The following is a description of a gene set: studied in species Homo sapiens The directed movement of substances into, out of, or within the nucleus. Human Gene Set: GOBP_NUCLEAR_TRANSPORT, and this is the list of marker genes: XPO5 (exportin 5), TNPO2, AKAP8L, LZTS2, NUP85, UHMK1, EIF4E, PTTG1IP, HDAC3, NRDE2, ATXN1, RPL23, CTDSPL2, XPO6, NUP35, IL1B, CDAN1, HSPA9, NUP62CL, THOC7, NPM1, ANKLE1, NUP160, EIF6, LEP, HCLS1, CDKN1B, DMAP1, C12orf50, IER3, PPP1R12A, PKIA, SHH, TSC2, SIRT6, KPNA1, CDKN2A, ZIC1, THOC2, KPNA7, SETD2, HIKESHI, PHB2, PARK7, RGPD3, THOC3, RAPGEF3, NFKBIA, DDX39B, EP300, THOC5, MAPK14, SFN, ZC3H12A, FAM53C, ING1 (inhibitor of growth family member 1), NUP43, AKT1, WNK1, CWH43, UPF2, ENY2, CFL1, RANBP1, SIX3, CPSF6 (NCBI Gene Id 11052), NR4A1, CDK1, TRAF3IP2, AHCTF1, MDN1, CCHCR1, YTHDC1, BAG3, PKD1, HEATR3, NUP107, TNPO1, DDX25, XPOT, FMR1, SRSF3, STRADA, TERT, FCHSD1, RAB23, PPP3R1, FERMT1, MED1, SMG7, NPAP1, TPR, NUP133, SARNP (SAP domain containing ribonucleoprotein), BCL3, UFM1, EPM2A, YWHAE, ZC3H11C, BMP4, GLI3, POLA2, RBM8A, HNRNPA1, RBM10, XPO4, MCM3AP, RANBP2, UBE2I, NSUN2, NXT2, CRY2, GAS6, EIF4A3, STRADB, PTPN14, CITED1, FRAT2, ANKRD54, PIK3R1, RPAIN, RBM15B, NEDD4, NEMF, TRIM28, THOC6, RGPD5, NXF1, SPG11, NMD3, SQSTM1, ZC3H11B, ADAR, SEH1L, PML, STAT3, RBM22, MAGOH, CHTOP, IPO11, STK3, TARDBP, HYAL2, ANP32B, AGFG1, RBM33, APPL1, NUP155, IPO4, NOTCH1, DRD1, TNPO3, SDAD1, CABP1, NUP93, SYK, KHDRBS1, RAN, KPNA2, NUP88, KPNA4 (NCBI Gene Id 84857), FGF9, JAK2, FAM53A, SMG5, SSB, APOD, EMD, PRKCD, NXF3, MX2, NCBP1, HHEX, SMG1, NUP188, HTATIP2 (HIV-1 Tat interactive protein 2), TMCO6, RPS15, LSG1, WASHC4, NUTF2, PTPN11, NEAT1, AKIRIN2, IPO13, NUP214, SMAD3, PRKD1, CALR, PSEN1, KCNQ3, RAE1 (NCBI Gene Id 8480), GLE1, RGPD1, DDX19A, NXF2, AHCYL1, DHX9, YWHAB, CAMK1, AXIN1, RBM4, FYTTD1, NUP54, ZC3H11A, NDC1, CHP1, FAM53B, RGPD6, XBP1, NUP210, RANBP6, BACH2, ANGPT1, TMEM53, UPF1, JUP, NXF5, FLNA, POM121B, ALYREF, RANGAP1, APPL2, CD36, MDFIC, GSK3B, NOL6, XPO1, CHP2, MALT1, CDH1, MAGOHB, KPNA5, SPRN, MMP12, KPNA3, FAM76B, NUP37, TP53, TXNIP (NCBI Gene Id 10628), SMO, POM121, PRKAG1, LRRK2, IWS1, CDKN1A, EGR2, RGS14, RANBP3L (NCBI Gene Id 202151), NOP9, POM121C, KPNA6, EFCAB7, CASC3, FRAT1, IL33, RGPD8, IPO5, E2F3, AAAS, ALKBH5, SMURF1, IFI27, PPM1A, IPO8, RGPD2, NUP58 (NCBI Gene Id 9818), PPP1CC, NUP42, CSE1L, KPNB1, SNUPN, SIRT7, ECT2, SMG6 (NCBI Gene Id 80091), HSP90AA1, ANP32CP, IPO7, CBLB, RANBP17, ANP32A, PRICKLE1, RANBP3, STK4, SIX2, NXT1, BARD1, MBTPS1, POLDIP3, RSRC1, GCKR, FBXO22 (F-box protein 22), SEC13, PHAX, NUP62, HSPA12A, HNRNPA2B1, LMNA, DDX19B, IPO9, THOC1, CDK5, PPP3CA, SEM1, MAVS, NUP205, ZPR1, POM121L2, SUMO1, RITA1, NCBP3, IFNG, MDM2, NUP98 (NCBI Gene Id 51457), SUFU, EI24, NF1, PPP1R10, ELAVL1, PRKACA, PKIG, TGFB1, ATF2, ABRA, NUP153, NCBP2, XPO7, SP100, NXF2B, PCID2, RGPD4, PIK3R2, DDX39A, UBR5, RIOK2, LTV1, EIF4ENIF1, PABPN1, DESI1, TXN, NUP50, PRP4K